Given this list of marker genes ATP2B2, GJB2, ESPN, HGF, IGF1, ADCY1, MARVELD2, GJB6, GIPC3, RIPOR2, TIMM8A, IARS2 (NCBI Gene Id 55699), CDH23, here is a description of the gene set: species: Homo sapiens Prelingual sensorineural hearing impairment Human Gene Set: HP_PRELINGUAL_SENSORINEURAL_HEARING_IMPAIRMENT A form of sensorineural deafness with either congenital onset or infantile onset, i.e., before the acquisition of speech.